The following is a description of a gene set: species: Homo sapiens Human Gene Set: GOMF_MODIFIED_AMINO_ACID_TRANSMEMBRANE_TRANSPORTER_ACTIVITY Enables the transfer of modified amino acids from one side of a membrane to the other., and this is the list of marker genes: SLC25A40, SLC25A20, SLC25A32, ABCC5, SLC16A12, SLC46A1, SLC7A9, GJA1, SLC25A13, SLC6A20, SLC25A26, SLC6A8, SLC6A13, SLC3A1, ABCC4, SLC22A15, SLC19A1, SLC5A6, SLC22A5, SLC22A1, CTNS, SLC19A2, SLC13A3, PDPN, SLC1A4, SLC22A4, ABCC1, SLC25A39, SLC7A11, SLC16A9, SLC25A12, SLC6A14 (NCBI Gene Id 282807), SLC22A16